Given this list of marker genes Gm8369, Klf11 (Kruppel-like transcription factor 11), Wdr33, Dennd1b, Rpl39, Gpr174, Ap1ar, Fam120a, Lyz3, Mcmdc2, Ppm1b, Clec1a, Hps1, Hdac3, Ccng1, Brpf1, Mbtd1, Ap3s1, Sumo1, Frmd5, Akap11, Adgrf2, Map2, Mtcl3, Pglyrp4, Tsc22d2, Cks2, Gpr50, Homer2, Tmem132d, Sdc2, Ust, Insyn2a, Ap1s2, Rad51b, Slc35g1, Lgals12, Rngtt, Syn2, Lox, Tshz1 (teashirt zinc finger family member 1), Camsap2, Gnai1, Stk36, Irf2bp2, Epb41l3, Csnk1d, Pafah1b1, Ints15, Ubl4a, Gm11780, Alx1, Strn, Cmpk1 (NCBI Gene Id 66588), Ica1l, Neurod4, Rabep1, Arfip2, Ocln, Cnep1r1, Dnajc3, Prdm2, Sgpp2, Uqcrfs1, Rnf149, Ppm1d, Slc8a1, Slc4a7, Klf4, Purg, Shq1, Pomc, Jazf1, Sec23a, Sftpa1, Prr14l, Cep170, Pcdhb3, Nfib, Gtf2i, Zxdb, Rpp25, Spred1, Slc35f1, Plppr5, Hvcn1, Cap1, Ube2q2, Usp46, Fbxo30, Il1rl1, Bcl7a, Wapl, Relch, Ago1, Appbp2, Il13ra1, Unc13c, Acot11, Wnt11, Ammecr1, Ccdc88a, Hlf, Rpl36a, Sec24c, Cbx3, Wwp1, Snx27, Trps1, Dclre1c, Lcorl, Ormdl2, Lhx6, Pyroxd2, Pdlim5, Rab11fip1, Aco1, Stam, Slc6a14, Mmp1b, Kctd12b, Dynlt3, here is a description of the gene set: Genes predicted to be targets of miRBase v22 microRNA mmu_miR_471_3p in miRDB v6.0 with MirTarget v4 prediction scores > 80 (high confidence targets). Mouse Gene Set: MIR_471_3P species: Mus musculus from publication Chen Y, Wang X (PMID 31504780)